The following is a description of a gene set: The directed movement of an acetate ester into, out of or within a cell, or between cells, by means of some agent such as a transporter or pore. studied in species Homo sapiens Human Gene Set: GOBP_ACETATE_ESTER_TRANSPORT, and this is the list of marker genes: SLC22A4, SLC17A8, ADORA2A, SLC44A4, TACR2, CHRNA3 (cholinergic receptor nicotinic alpha 3 subunit), SLC18A3, SLC22A1 (NCBI Gene Id 6580), SLC22A2